The following is a description of a gene set: species: Homo sapiens Integration of provirus Human Gene Set: REACTOME_INTEGRATION_OF_PROVIRUS, and this is the list of marker genes: PSIP1, XRCC4, KPNA1, XRCC5 (NCBI Gene Id 7520), PPIA, BANF1, LIG4, HMGA1, XRCC6